The following is a description of a gene set: Any process that results in a change in state or activity of a cell (in terms of movement, secretion, enzyme production, gene expression, etc.) as a result of a parathyroid hormone stimulus. studied in species Homo sapiens Human Gene Set: GOBP_CELLULAR_RESPONSE_TO_PARATHYROID_HORMONE_STIMULUS, and this is the list of marker genes: KAT2B (lysine acetyltransferase 2B), HDAC6, PRKACA, FGF23, SOST, SLC34A1, PHEX, HDAC3, FOS, MEF2C, WNT10B